Given this list of marker genes ASCL1, NFE2L1, HOXB8, LHX3 (LIM homeobox 3, NCBI Gene Id 8022), HOXD10, FOXB1, PLXDC1, NEUROG3, GSX2, GRIA1, DAAM2, NOTCH1, HOXC10, IFT122, DLL4, SCYL3, ABT1, GATA2, MDGA2, LHX4, PTCH1, VLDLR, PROX1, LONRF2, IFT172, IFT80 (NCBI Gene Id 57560, intraflagellar transport 80), NOG, SRD5A1, PTBP2, DAB1, MDGA1, MPST, WNT1 (NCBI Gene Id 7471), NPFF, SLIT1, DRGX, DLL1, TAL1, MED12, LMO4, MNX1, GBX1, EED, PKD1, ISL1, PHOX2A, LRP8, SOX4, PAX7, GLI3, GDF11, SOX12, VIT, ISL2, NF1, GIGYF2, OLIG3, LHX1, TCTN1, INTU, NEFL, ERCC2, ZC4H2, GSX1, DCC, TBX20, UNCX, GDNF, CLN8, SOX1, PTPRS, VSTM5, LHX5, SOX11, ACTL6A, ZIC1, LOXL3, LBX1, GDF7, GLI2, PAX6, PBX3, PHGDH, SUFU, SHH, CHRD, NKX2-2, SOX13, BAG3, DRAXIN, PKD2, DCTN1, FOXN4, RELN, OLIG2, ZPR1, SMO, ADARB1, DBX1, SOX6, DYNC2H1, WNT3A, SCYL1, DMRT3, here is a description of the gene set: species: Homo sapiens The process whose specific outcome is the progression of the spinal cord over time, from its formation to the mature structure. The spinal cord primarily conducts sensory and motor nerve impulses between the brain and the peripheral nervous tissues. Human Gene Set: GOBP_SPINAL_CORD_DEVELOPMENT